Given this list of marker genes TNFSF4, P2RY11, KCNT1, SLC25A13 (NCBI Gene Id 10165), CRH, HLA-DQB1, HLA-DRB1, SMO, CTSH, ZNF365, HCRT, CABP4, CHRNA4 (NCBI Gene Id 1137), DEPDC5, MOG (NCBI Gene Id 4340), MTFMT, CHRNB2, CHRNA2, here is a description of the gene set: A parasomnia that occurs during non-rapid eye movement (NREM) sleep. Human Gene Set: HP_NREM_PARASOMNIA NREM parasomnia species: Homo sapiens